The following is a description of a gene set: Any process that results in a change in state or activity of a cell or an organism (in terms of movement, secretion, enzyme production, gene expression, etc.) as a result of a fungicide stimulus. Fungicides are chemicals used to kill fungi. studied in species Mus musculus Mouse Gene Set: GOBP_RESPONSE_TO_FUNGICIDE, and this is the list of marker genes: Kdm6b, Ehmt1, Gria1, Kdm1a, Kdm5b, Hif1a, Star, Ehmt2